Given this list of marker genes Bmp2, Nr3c1, Hsd11b1, Nr5a2, Bmp5, Cacna1h, Cyp17a1, Crh, Dkk3 (NCBI Gene Id 97412), Cyp11b2, H6pd (NCBI Gene Id 14379), Cyp11a1, Wnt4, Dgkq, Cyp11b1, Rest, Atp1a1, Cyp21a1, here is a description of the gene set: The chemical reactions and pathways resulting in the formation of glucocorticoids, hormonal C21 corticosteroids synthesized from cholesterol. Mouse Gene Set: GOBP_GLUCOCORTICOID_BIOSYNTHETIC_PROCESS species: Mus musculus